Given this list of marker genes Tpm1, Adrb2, Adra1b, Drd5, Adra1d, Adra1a, Adrb1, Adrb3, here is a description of the gene set: species: Mus musculus The process in which the secretion of norepinephrine or epinephrine into the bloodstream modulates the force with which blood passes through the circulatory system. Mouse Gene Set: GOBP_REGULATION_OF_SYSTEMIC_ARTERIAL_BLOOD_PRESSURE_BY_NOREPINEPHRINE_EPINEPHRINE